Given this list of marker genes SLC24A3, SLC24A4, SLC8A3, SRI, SLC24A1, SLC8B1, SLC24A2, CALM1, SLC8A2 (solute carrier family 8 member A2), SLC8A1, SLC24A5, here is a description of the gene set: Human Gene Set: REACTOME_SODIUM_CALCIUM_EXCHANGERS studied in species Homo sapiens Sodium/Calcium exchangers